Given this list of marker genes S100A14, CXCL8 (C-X-C motif chemokine ligand 8), IL12A, TRPV4, VEGFC, CALR (calreticulin), CXCL12, NCKAP1L, CCL2, CCL5, WNT5A, DEFB131A, MAPK3, DNM1L, CSF1, EDN3, AKIRIN1, DEFB124, OXSR1, SWAP70, MSTN, EDN1, SPI1, XCL1, WNK1, VEGFD, CXCL17, HMGB1, MAPK1, DAPK2, CCR1, TNFSF18, CCR6, PGF, CAMK1D, THBS4, FPR2, CXCL13, SLAMF1, C1QBP, TIRAP, VEGFA (NCBI Gene Id 7422), S100A7, GAS6, IL6R, IL34, CSF1R, F2RL1, CXCL10, MCU, IL6, ADAM17, TNFSF14, CCL19, PERP, AIF1, RARRES2, C5AR1, GPSM3, PTK2, RAC1, CCR7, LGMN, CCL1, PTPRJ, NEDD9, EDN2, C3AR1, PTN, STK39, RAC2, VEGFB, SERPINE1, CD74, THBS1, APP, MOSPD2, CCL3, PLA2G7, ANO6, CCR2, TMEM102, MDK, PTK2B, LBP, CCL7, ZNF580, CCL4, CX3CR1, RIPOR2, CMKLR1, CREB3, ADAM10, LGALS9, F7, IL23A, CCL21, here is a description of the gene set: Any process that activates or increases the frequency, rate, or extent of leukocyte chemotaxis. Human Gene Set: GOBP_POSITIVE_REGULATION_OF_LEUKOCYTE_CHEMOTAXIS species: Homo sapiens